Given this list of marker genes ARL6, BBS1, AQP2, VIPAS39, AVPR2, CCDC28B, CRLS1, VPS33B, here is a description of the gene set: Nephrogenic diabetes insipidus Human Gene Set: HP_NEPHROGENIC_DIABETES_INSIPIDUS studied in species Homo sapiens A form of diabetes insipidus caused by failure of the kidneys to respond to vasopressin (AVP).